The following is a description of a gene set: Human Gene Set: GSE14026_TH1_VS_TH17_UP from publication Lee YK, Turner H, Maynard CL, Oliver JR, Chen D, Elson CO, Weaver CT (PMID 19119024) Genes up-regulated in comparison of Th1 cells versus Th17 cells. This is to compare the gene expression profile of Th1 and Th17 cells. species: Homo sapiens, and this is the list of marker genes: SEMA3G, TACSTD2, CBLN1, CRYL1, CLEC18A, IL17B (interleukin 17B), HSPD1, CHPF2, PCDHAC1, DLL1, GMEB2, NAA11, ZNF354B, SSTR1, PPP1R3A, ADORA3, ZBTB1 (zinc finger and BTB domain containing 1), STAT5A, SMURF1, GRIP2, PCDHB3, ELOA, UBTFL1, MYO10, SPATA3, SRPRB, SLC7A5, PPP1R14D, FBXO27, KRT222, OPRD1, GSG1, HK3, LCMT2, SPATA19, RNF182, TREH, PRAMEF12, TRIM65, NAGPA, ZNF777, MTARC1, VSNL1, BFAR (NCBI Gene Id 51283), TAFA1, TRAF3, BCL7B, DNASE1L3, NAB2, ATP13A1, SZRD1, EFS, ENTPD6 (ectonucleoside triphosphate diphosphohydrolase 6), KRT32 (keratin 32), FBXO31, TBKBP1 (TBK1 binding protein 1), SOD3, NLRP12, SLC35C2, CCT2, AMELX, ANXA10, CXorf49B (chromosome X open reading frame 49B), USP10, CLCA2, SALL4, CRLS1, TRMT2A, TRPV1, FKRP, SLC5A9 (NCBI Gene Id 200010), PDCD7, GLRA1, ZNF418, ZGLP1, PGAP6, MORC1, MSR1, SOX2-OT, TMEM119, CHD7, SERPINB12, IL9R, ADAM2, GPR179, BOLL, NOC2L, LGALS12, NCAN, P2RX5, PTPRO, C3orf22, CYB5RL, CACTIN, KLF16, CACNB2, ENTR1, HAO2, ADD2, WIPF1, MAML2, DNASE1, FAM222B, LCP1, ETNPPL, TMEM171, B3GALT6, SRM, ASAH2 (NCBI Gene Id 63292), ANXA13, DPYSL5, EIF3B, FBRS, PPP4R3A, ZNF346, CSRNP2, HMGXB3, TCEAL7, ATP10B (ATPase phospholipid transporting 10B (putative)), PNLIP, SPMAP2, SLCO6A1, EFCAB12, GABRG2, RBM15B, GPIHBP1, CAMSAP1, DACT1, CYP2R1, FASN, PRDM4, TGFB1I1, ROBO1, LRP3, LRRC3, MOCS3, OTUD3, NOL4, DGCR2, ADRM1, BEX4, N6AMT1, MATN1, TNR (tenascin R), KCNH3, KRT39, MARCHF4, PCBP1, RNF139, LATS2, HIRIP3, MIA2, CCND2, KRT2, POLR1G, SPNS3, ZNF420, ESS2, NUDT11, SLC35A4, RBMXL2, SLC40A1, TMEM190, SF3A2, FPR1, MCRIP2, RGMA, CTSG, CSF2RB, DHODH, GRIN3A, PPM1G, ZNF750, BCL7A, IL11, MDK (midkine), LAMA2, MEFV, SLC30A5, PDCD2L, C16orf96, SUPV3L1, CDK3, SPMIP9, BAHD1, C10orf62, PCOLCE2, MLST8, SPRR2A, RBMS3, THOC5, CACNB4, TMEM266, ELAVL4, DLG5, IL21R, APC2, SLC37A1, SENP3, ASAP1